Given this list of marker genes PIP5K1B, C3AR1, DEGS1, APBB1IP, MYO10, MAP2K1, EIF1, SQSTM1, BCL6B, TNIP1, CD44, GCH1, PTGS2, SLPI, CASP4, ATF3, ETS2, MT1X, TOP1, TXNRD1, SLC2A1, TGFB1, WSB1, SLC11A1, HCK (HCK proto-oncogene, Src family tyrosine kinase), LCP2, TPST1, NFKBIA, MYADM, RGS16, BCL2L1, PML, LTB, MAPKAPK2, DAB2, MSR1, JUND, SAT1, HCLS1, TNFSF9, ACSL4, IRGM, PYHIN1, SAP30, MARCKSL1, RNF11, NFKB1, CCL3 (C-C motif chemokine ligand 3), HMGCR, RHOC, CDKN1A, IFRD1, SLC20A1, FURIN, MLLT11, CCL15, CITED2, RCN1, TNF, ADAR, GK, ETF1, PNP (NCBI Gene Id 4860), GLRX, KPNA3, SLFN12, TRIM25, FCGR2B (NCBI Gene Id 2213), SRGN, ODC1, TNFRSF1B, TAP1, CLN3, IER2, CLEC4D, IER3, IL1RL1, STAT1, STK10, PRKCD, CEBPD, IL1RN, CFLAR, here is a description of the gene set: from publication Németh ZH, Leibovich SJ, Deitch EA, Vizi ES, Szabó C, Hasko G (PMID 12766259) Adenosine is released into the extracellular space from nerve terminals and cells subjected to ischemic stress. This nucleoside modulates a plethora of cellular functions via occupancy of specific receptors. Adenosine is also an important endogenous regulator of macrophage function, because it suppresses the production of a number of proinflammatory cytokines by these cells. However, the mechanisms of this anti-inflammatory effect have not been well characterized. We hypothesized that adenosine may exert some of its anti-inflammatory effects by decreasing activation of the transcription factor nuclear factor-kappaB (NF-kappaB), because gene expression of most of the proinflammatory cytokines inhibited by adenosine is dependent on NF-kappaB activation. Using bacterial lipopolysaccharide (LPS)-stimulated RAW 264.7 macrophages, we found that adenosine as well as adenosine receptor agonists decreased the production of tumor necrosis factor (TNF)-alpha, a typical NF-kappaB-regulated cytokine. This effect of adenosine was not due to an action on the process of TNF-alpha release, because adenosine suppressed also the intracellular levels of TNF-alpha. However, cDNA microarray analysis revealed that mRNA levels of neither TNF-alpha nor other cytokines were altered by adenosine in either LPS-activated or quiescent macrophages. In addition, although LPS induced expression of a number of other, noncytokine genes, including the adenosine A2b receptor, adenosine did not affect the expression of these genes. Furthermore, adenosine as well as adenosine receptor agonists failed to decrease LPS-induced NF-kappaB DNA binding, NF-kappaB promoter activity, p65 nuclear translocation, and inhibitory kappaB degradation. Together, our results suggest that the anti-inflammatory effects of adenosine are independent of NF-kappaB. species: Mus musculus Genes up-regulated in RAW 264.7 cells (macrophage) 3 hr after stimulation with bacterial lipopolysaccharide (LPS). Human Gene Set: NEMETH_INFLAMMATORY_RESPONSE_LPS_UP